The following is a description of a gene set: from publication Zhan F, Huang Y, Colla S, Stewart JP, Hanamura I, Gupta S, Epstein J, Yaccoby S, Sawyer J, Burington B, Anaissie E, Hollmig K, Pineda-Roman M, Tricot G, van Rhee F, Walker R, Zangari M, Crowley J, Barlogie B, Shaughnessy JD Jr (PMID 16728703) To better define the molecular basis of multiple myeloma (MM), we performed unsupervised hierarchic clustering of mRNA expression profiles in CD138-enriched plasma cells from 414 newly diagnosed patients who went on to receive high-dose therapy and tandem stem cell transplants. Seven disease subtypes were validated that were strongly influenced by known genetic lesions, such as c-MAF- and MAFB-, CCND1- and CCND3-, and MMSET-activating translocations and hyperdiploidy. Indicative of the deregulation of common pathways by gene orthologs, common gene signatures were observed in cases with c-MAF and MAFB activation and CCND1 and CCND3 activation, the latter consisting of 2 subgroups, one characterized by expression of the early B-cell markers CD20 and PAX5. A low incidence of focal bone disease distinguished one and increased expression of proliferation-associated genes of another novel subgroup. Comprising varying fractions of each of the other 6 subgroups, the proliferation subgroup dominated at relapse, suggesting that this signature is linked to disease progression. Proliferation and MMSET-spike groups were characterized by significant overexpression of genes mapping to chromosome 1q, and both exhibited a poor prognosis relative to the other groups. A subset of cases with a predominating myeloid gene expression signature, excluded from the profiling analyses, had more favorable baseline characteristics and superior prognosis to those lacking this signature. Top 50 up-regulated genes in cluster HP of multiple myeloma samples characterized by a hyperploid signature. species: Homo sapiens Human Gene Set: ZHAN_MULTIPLE_MYELOMA_HP_UP, and this is the list of marker genes: NOP53, FCHSD2, PIP5K1B, VPS51, F2R (coagulation factor II thrombin receptor), DELE1, OAS2, ATP5MG, RPL37, GTF2F2, EPB41L4A-AS1, RBM4, SCYL2, EIF3F, SEMA4D, RIGI, GNG11, FLI1, SIDT1, PAK1, TNFSF10, TRABD2A, LAMP3, RPS17P5, CSNK1G3, RSAD2, CCDC85A, IPO7, ELOVL7, SCAMP1-AS1, CDV3, CCRL2, ZFAS1, RPL13A, SCAPER, ISL2, SNHG7, CNTN5, LAG3, CCR5, THG1L, POLR1D, AMIGO2, GBA3, FRZB, XRCC4, EPHB1, RPL7AP10, RC3H2